The following is a description of a gene set: studied in species Homo sapiens Vitamin D (calciferol) metabolism Human Gene Set: REACTOME_VITAMIN_D_CALCIFEROL_METABOLISM, and this is the list of marker genes: GC, PIAS4, LRP2, CYP24A1, SUMO2, LGMN, VDR, CYP2R1, LDLRAP1, CUBN, CYP27B1, UBE2I (NCBI Gene Id 7329)